Given this list of marker genes Top1, Dhx9, Xlr4b, Kash5, Ccnb1ip1, Gm5935, Pole3, Chek1, P3h4, Tex11, Xlr5a, Trrap, Smchd1, Orc3, Ik, Tipin, Pold3, Srsf2, Syce1l, Phf12, Fkbp6, Pold4, Gm28961, Syn1, Atf6b, Zranb3, Gon4l, Lrpprc, Rad21l (RAD21-like (S. pombe), NCBI Gene Id 668929), Pold1, Tex12, Gm29276, Hdac1, Ercc5, Gm10230, Gins1, Morf4l1, Cdc5lrt6 (NCBI Gene Id 668203), Nifk, H3f5, Gm29866, Trex1, Ncapd2, Orc5, Sirt7, Yy1, Cdc5lrt9, Brd4, Polb, Cdc5lrt5, Gm5168, Smarcal1, Ncaph2, H3f3a-ps1, Etaa1 (Ewing tumor-associated antigen 1), Swi5, Clock, Smc3, Gm21865, Gins3, Mcm7, Pinx1, 3830403N18Rik, Ncaph, 1700013H16Rik, Lrwd1, Brca2, Trim24, Tonsl, Gm1993, Slx1b, Sin3a, Mlh1, Rpa3, H3f3a, Ino80, Tet1, Airn (NCBI Gene Id 72704), Gm7958, Ncapg2, Mcm6, Hormad2 (NCBI Gene Id 75828), Ttn, Baz1b, Zmiz2, Hmg20b, Psmc3ip, Gm29554, Xlr3b, Rsph1, Ino80b, Smc1a, Brca1, Birc5, Gm20817, Ruvbl2, Gm4297, Kmt2e, Sycp2l, H3f3a-ps2, Hus1, Rad50, Rnf212, Uchl5, Macroh2a2, Mre11a, Xlr, Baz1a, Cdc5lrt4, Gm1140, Smarca5, Nfrkb, Gm21996, Rad9a, Rec8, Rad9b, Fignl1, Rad1, Orc2, Gm21858, Syce2, Hnrnpu, H1f6, Xlr4a, Ing3, Ino80c, Lrif1, Sfr1, Xlr5b, Gm28576, Macroh2a1, Stag3, Setx, Cfdp1, Dnmt3l, Mms22l, Srcap, Ing1, Gm21095, Kat5, Gm21627, Cdc5l, Blm, Lig3, Sap130, Gm28510, Ino80d, Setd5, Mus81, Slxl1, H2az1, Suds3, Mcm2, Smarcb1, Prim1 (NCBI Gene Id 19075), Msh4, Xlr5c, Incenp, Ogt, Smarcad1, Csnk2a1, Slx, Nek2, Gm20820, Actr6, Rrs1 (ribosome biogenesis regulator 1), Mcm5, Pole4, Pola2, Smc4, Gins4, Rbbp4, Ing2, Rcc1, Rad21, Topbp1, Plk1, Dmc1, Bcas2, Hmga2, H2ax, Pole2, Orc6, Gm14525, Xlr3a, Eme1, Tubg1, Gm10257, Gm2012, Arid4a, Prpf19, Gm20911, Smc1b, Sinhcaf, Gm20824, Arid4b, Slx4, Helb, Hdac2, Gm6421, Zbtb32, Hormad1, Spidr, Hus1b, Orc1, Gm28919, Slc5a8, Actr8, Timeless, Gm773, Mcm10, Rbbp7, Syce1, Xlr4c, Anp32e, Pold2, Rad51, Xpa, Rnf212b, Xlr3c, Brd8, E2f1, Gm20736, Sap30l, Actl6a, Smc2, Ruvbl1, Sun2, Gins2, Spo11, Eme2, Sycp3, Ago3 (NCBI Gene Id 320115), Ep400, Actr5, Gm28102, Syce3, Iho1, Plrg1, Cdc5lrt10, Mlh3, Gm6121, Gm20843, Chd1, Mcm4, Pcna, Add3, Gm21294, Gm5934, Gm2030, Ncapd3, Msh5, Gm28870, Sycp2, 4930447C04Rik, Gm5169, Nufip1, Wdhd1 (WD repeat and HMG-box DNA binding protein 1), Prim2, Sap30, Pole, H3f3c, Cdc5lrt1, Cdc5lrt7, H3f4, Dmap1, Cdx2, Ino80e, Hcfc1, Orc4, Mcrs1, Parp1, E2f6, Cdc5lrt8, Cdc45, Kifap3, Mei4, Top2a, Atrx, Tfpt, Brms1l, Brms1, Tardbp, Rpa2, Exosc9, Nol6, Gm21117, Mcm3, Sin3b, Gm20890, Shoc1, Gm10488 (NCBI Gene Id 100042109), Smarca4, Nat8, Chmp1a, Carm1, Znhit1, Gm20870 (NCBI Gene Id 73329), Gm21760, Rpa1, Hspa2, Pola1, Cpsf6, Sycp1, here is a description of the gene set: A chromosome that encodes the nuclear genome and is found in the nucleus of a eukaryotic cell during the cell cycle phases when the nucleus is intact. Mouse Gene Set: GOCC_NUCLEAR_CHROMOSOME species: Mus musculus